The following is a description of a gene set: Mouse Gene Set: chr12A2 species: Mus musculus, and this is the list of marker genes: Gm20208, 1700020D12Rik, Dld, C630031E19Rik, Gm25408, Gm18502, Gm28806, Gm29687, Rnaseh1, Tmem18, Rsad2, Gm32443, Tpo, Mir6538, Gm32899, Gm29968, Myt1l (NCBI Gene Id 73066), Ryk-ps1, Rnf144a, Gm24326, Allc, Bcap29, Gm15691, Colec11, Gm46344, Fam110c, Rps7, Gm6993, Gm6992, Gm18024, Gm31508, Slc26a4, 4833405L11Rik, Sh3yl1, Adi1, Mir6937, Sntg2, Gm9359, Eipr1, Pxdn, Lamb1, Slc26a3, Alkal2, 2310016D03Rik, Dus4l, Acp1, Gm31333, 4933409F18Rik, Sox11, Gm45941, Gm24613, Cog5, 6030469F06Rik, Gm6989, Cmpk2, Gm31025, Gm4166, Trappc12, Dcdc2c, Cbll1, 4930549C15Rik, Silc1, 4930480M12Rik